The following is a description of a gene set: Genes predicted to be targets of miRBase v22 microRNA mmu_miR_6989_5p in miRDB v6.0 with MirTarget v4 prediction scores > 80 (high confidence targets). Mouse Gene Set: MIR_6989_5P studied in species Mus musculus from publication Chen Y, Wang X (PMID 31504780), and this is the list of marker genes: Nmrk1, Zfp219, Fgfr2, Sirt2, Scn7a, Rxrg, Zfp207, Nos1, Ttll5, Gipc1, Kcne4, Luzp1, Cox16, Spry4, Slc25a27, Cdc37, Capn5, Pde1c, Clip3, Cplx2, Cwc15, Stag3, Dtna, Smg7, Gfra3, Gcsam, Dtx4, Nktr, Btbd2, Plxna1, Lat, S2bpcox16, Aoc3, Masp1, Specc1, Zfp39, Mettl2, Or2ag2b, Des, Gpalpp1, Ifnlr1, Spata31d1c, Fads1, Sh3pxd2a, Cacna2d2, Thsd4, Pip5k1c, Tsr2 (NCBI Gene Id 69499), Ntn3, Pllp (plasma membrane proteolipid), Dchs1, Tram1, Xndc1, Ank3, Fcrla, Elavl3, Acvr2b, Grhl2, Sh2d7, Hspb6, Clock, Cd55, Zfand2a, Cck, Nr1d2, Mustn1, Dspp, Astl, Dcc, Kcnk3, Ren1, Prdm12, Chdh, Agtr1b, Fut8, Tyrobp, Atxn7l3, Nme4 (NME/NM23 nucleoside diphosphate kinase 4), Rnf122, Rai14, Nectin2, Dzip1l, Ppp1r13l (protein phosphatase 1, regulatory subunit 13 like), Hipk1, Cflar, Gimap6, Krt6a, Sypl2, Ehd4, Myrf, Tgm3 (NCBI Gene Id 99129), Tnfrsf19, Slc12a5 (NCBI Gene Id 57138), Map3k9, Csgalnact2, M6pr, Ttc7b (NCBI Gene Id 217829), Fam186b (NCBI Gene Id 636834), Lrrc75a, Chpt1